Given this list of marker genes KCNQ2, COG2 (component of oligomeric golgi complex 2), SCN8A (sodium voltage-gated channel alpha subunit 8), CLN3, KMT2A (lysine methyltransferase 2A), RRM2B, PLA2G6, GALC, PSAP, PRRT2, GALK1, ATP6V0A2, ATP6V1E1, ATP6V1A, HEXA, PLP1, PPT1, KCNQ3, SCN2A, RNASEH1, here is a description of the gene set: Psychomotor deterioration Human Gene Set: HP_PSYCHOMOTOR_DETERIORATION Loss of previously present mental and motor abilities. studied in species Homo sapiens